The following is a description of a gene set: Any process that stops, prevents or reduces the frequency, rate or extent of autophagosome maturation. studied in species Mus musculus Mouse Gene Set: GOBP_NEGATIVE_REGULATION_OF_AUTOPHAGOSOME_MATURATION, and this is the list of marker genes: Clec16a, Ubqln4, Phf23, Tmem39a, Rubcn